Given this list of marker genes MUTYH, here is a description of the gene set: part of: Defective Base Excision Repair Associated with MUTYH For a subset of MUTYH disease variants underlying MUTYH-associated polyposis (MAP), also known as familial adenomatous polyposis 2 (FAP2), it was shown that, in addition to impaired catalytic activity, they also exhibit reduced binding to their substrate, adenine mispaired with 8-oxoguanine (OGUA:Ade, also known as 8-oxoG:A). MUTYH alpha-3 isoform (MUTYH-3) mutants with demonstrated deficient binding to OGUA:Ade include missense variants MUTYH-3 Y165C, MUTYH-3 R227W, MUTYH-3 R231L, MUTYH-3 R231H, MUTYH-3 V232F, MUTYH-3 R260Q, MUTYH-3 P281L and MUTYH-3 G382D, nonsense variants MUTYH-3 Y90*, MUTYH-3 Q377*, MUTYH-3 E466*, and frameshift variant MUTYH-3 A368fs26* (commonly known as MUTYH 1103delC). Reactome Pathway: Defective MUTYH substrate binding studied in species Homo sapiens